The following is a description of a gene set: studied in species Homo sapiens Human Gene Set: REACTOME_REGULATION_OF_TBK1_IKK_MEDIATED_ACTIVATION_OF_IRF3_IRF7_UPON_TLR3_LIGATION Regulation of TBK1, IKKε-mediated activation of IRF3, IRF7 upon TLR3 ligation, and this is the list of marker genes: RPS27A, TLR3, UBC, TRAF3, UBB, UBA52, TICAM1, OPTN, TANK, TBK1, IKBKE